The following is a description of a gene set: Human Gene Set: GOBP_REGULATION_OF_CHOLESTEROL_BIOSYNTHETIC_PROCESS Any process that modulates the frequency, rate or extent of the chemical reactions and pathways resulting in the formation of cholesterol. studied in species Homo sapiens, and this is the list of marker genes: LPCAT3, SREBF2, ABCG4 (NCBI Gene Id 64137), PRKACA, AQP8, MBTPS1, MIR98, MAPK1, GNAI1, MIR185, SREBF1, ABCA2, MBTPS2, MIR182, MIR548P, FGF1, MIR96, APOE, SEC14L2, ABCG1, PRKAA1, APOB, MIR30C1, KPNB1, CYP7A1, PAQR3, QKI, ERLIN2, ERLIN1, GPR146, SCAP (NCBI Gene Id 22937), INSIG1, MIR342, C7orf50